The following is a description of a gene set: species: Homo sapiens Human Gene Set: GSE6092_B_BURGDOFERI_VS_B_BURGDORFERI_AND_IFNG_STIM_ENDOTHELIAL_CELL_DN Genes down-regulated in endothelial cells: B. burgdoferi versus IFNG and B. burgdoferi. Borrelia burgdorferi, the agent of Lyme disease, promotes pro-inflammatory changes in endothelium that lead to the recruitment of leukocytes. The host immune response to infection results in increased levels of IFN-gamma in the serum and lesions of Lyme disease patients that correlate with greater severity of disease. Therefore, the effect of IFN-gamma on the gene expression profile of primary human endothelial cells exposed to B. burgdorferi was determined. B. burgdorferi and IFN-gamma synergistically augmented the expression of genes, seven of which encode chemokines. Six of these (CCL7, CCL8, CX3CL1, CXCL9, CXCL10, and CXCL11) attract T lymphocytes, and one (CXCL2) is specific for neutrophils. Synergistic production of the attractants for T cells was confirmed at the protein level. IL-1beta, TNF-alpha, and LPS also cooperated with IFN-gamma to induce synergistic production of CXCL10 by endothelium, indicating that IFN-gamma potentiates inflammation in concert with a variety of mediators. An in vitro model of the blood vessel wall revealed that an increased number of human T lymphocytes traversed endothelium exposed to B. burgdorferi and IFN-gamma, as compared to unstimulated endothelial monolayers. In contrast, addition of IFN-gamma diminished the migration of neutrophils across B. burgdorferi-activated endothelium. IFN-gamma thus alters gene expression by endothelium exposed to B. burgdorferi in a manner that promotes recruitment of T cells and suppresses that of neutrophils. This modulation may facilitate the development of chronic inflammatory lesions in Lyme disease. from publication Dame TM, Orenzoff BL, Palmer LE, Furie MB (PMID 17202382), and this is the list of marker genes: TRIP10, XKR8, PDSS1, CLDND1 (claudin domain containing 1), HDGF, HIVEP1, RNF19A, PRKCD, HAS1, EIF1AX, SLC39A1, GPR18, LMO4, BRAF, ITGA5, TMPRSS6, MTDH, EPHA4, KREMEN1, DCUN1D3, ABI1, TRIB1, FAM20B, TMEM123, LCN2, PHTF2, STX11, DNAJC2, VTA1, EIF3D (NCBI Gene Id 8664), CALCR, DGKH (NCBI Gene Id 8524), HDLBP, GADD45A, NCOA5, RRP15, CD14, NCK1, LTV1, HEG1, CPEB4, IL12A, OSBPL3, AGRN, BATF2, ZHX2, TNIP3 (TNFAIP3 interacting protein 3), CCDC88B, SLC16A3, SLC7A2, MORF4L2, NAB2, TSHZ1, LZTFL1, PLCL1, NSMF, NAMPT, IL12B, ST3GAL1 (ST3 beta-galactoside alpha-2,3-sialyltransferase 1), PNO1, BCORL1, DYNC1I2, DDX54, MRPL3, FMNL2 (formin like 2), DDHD1, KDR, PRPF38A (pre-mRNA processing factor 38A), SLC7A1, CALHM6, RIPK2 (receptor interacting serine/threonine kinase 2), GADD45B, BIRC2, GBP4, DUSP8, SEPTIN7, HTRA4, UBE2S, SERPINE1, RELB, KCNE5, GTPBP2, PSME3, HSD17B12, HIF1A, SLC16A10, TNFSF15, TRAF2, TAGAP, SAMSN1, KIF5B, SMURF1, VASH1, SHOC2, MARCO (macrophage receptor with collagenous structure), TLR1, SPN, PROCR, DRAM1, CS (NCBI Gene Id 94822), PRELID3B, TNFAIP3, SOCS1, PSMC4, IKZF1, AMD1, GPR85 (NCBI Gene Id 54329), RMDN3, PSMB10, HCAR2, NFKBIE, NOD1, CLEC4D (NCBI Gene Id 338339), TICAM2, TDRD7, LCAT, STIP1, PLAGL2, DENR, RGL1, NFE2L1, USP42, DUSP2, MAP2K1, SLC25A10, STARD5, PIK3R5, ST3GAL3, N4BP1, TMED5, TNFAIP2, CASP7, ACSL5, MKI67, F3, SPACA6, SDAD1, EREG, RRAS2, PPP2CA, PIK3CB, GPHN, CD274, F10, SLC39A14, EGR2, CXCL3, USP39, PIK3CG, MVP, RALGDS, TAPT1, PEX16, DDX39A, AEBP2, RNF19B, ABTB2, ITGAL, PRDM1 (PR/SET domain 1), MIER3, ZDHHC5, SYNCRIP, POLR2M, IL18, UBE2Z, CLINT1, ECI2, CP, MEX3C, ITGAX, APPL1, TNFRSF1B, SPATA13, MOCS1, GRAMD1A, PTPN12, WDR1, DDX60, ITGB8, GCA